Given this list of marker genes Nup62, Gpc4, Chsy3 (NCBI Gene Id 78923), B3gat2, Gpi1, Bpgm, Gns, Fut2, Tpi1, Stab2, Pfkfb2, Lalba, Chst11, Ogn, Chst13, Gpc3, Cryl1, Chst7, Abcc5, Fut4, B3galt2, Sdc1, Pfkl, Gck, Nup37, Pfkfb3, Sec13, Pygl, Lum, Khk, Pgm1, B4galt2, Chp1, G6pc2, Dcxr, B4galt7, Gpc2, Glb1l3, Ndst1, Fut1, Nup43, Nup214, Gapdhs, Pkm, Uxs1 (NCBI Gene Id 98712), Ugp2, Gckr, Sdc2, Gpc1, Akr1e1, Pygm, Agrn, Fbp1, Pgm2, Prelp, G6pdx, Hpse2, B4galnt2, Tkt, Prps1l1, Glb1, Eno4, Chst3 (NCBI Gene Id 53889), Gpc6, Nup205, Xylt2, Slc37a4, Has3, Hexa, Slc37a1, Papss2, Hs6st3, Csgalnact2, Fut7, Pfkm, Hmmr, Shpk, St3gal2, Dse, Slc9a1, Chst12, Ext1, Hs2st1, Chst5, Sgsh, Slc37a2, Man2b1 (mannosidase 2, alpha B1), B4galt1, Phka2, Seh1l, Pgd, Ndc1, Galk1, Hk3 (hexokinase 3), Bgn, Nup93, Xylb, Ids, Gpc5, Cemip, Kera, Xylt1, B3gnt3, Abo, Chst1, Prps1, Pgk2, Ust, Rpia, Hs3st3b1, Chpf, Aldob, B4galt3, Pfkfb4, Taldo1, Nup160, Omd, Agl, Nup42, Rae1, Glb1l2 (galactosidase, beta 1-like 2), Slc35d2 (NCBI Gene Id 70484), Nup35, Pgk1, Aldoc, Sord, Pgm2l1, Galns, Hs3st1, St3gal3, Tkfc, Galm, Chst2, Phkg1, Dera, Pck1, Nup88, Pcx, Man2c1, Hpse, Cspg5, Slc35b2, B4galt5, Fmod, Papss1, Tpr, Bcan, Prps1l3, Gale, Gbe1, Hs3st6, Slc26a2, Nup210 (NCBI Gene Id 54563), St3gal1, Calm1, Acan, Galt (galactose-1-phosphate uridyl transferase), Fut9, Csgalnact1, Ndst4, B3galt6, Sdc4, Hyal2, Manba, B3gnt2, Pfkp, B3gat1 (beta-1,3-glucuronyltransferase 1), Slc26a1, Ndst3, Pgam1, Hs3st5 (heparan sulfate (glucosamine) 3-O-sulfotransferase 5), Gaa, Chst15, Chsy1, Cd44, Nup133, Chst14, B4galt4, Pgls, Nup153, Aldh1a1, Naglu, Vcan, Calm2, Cspg4, G6pc1, Hyal1, Nup188, Rbks, Dsel, Aldoa (aldolase A, fructose-bisphosphate), Arsb (NCBI Gene Id 71784), Gnpda2, Hexb, B3galt4, Chpf2, Pgam2, Gnpda1, B4galt6 (NCBI Gene Id 56386), Lyve1, Eno3, Prps2, St3gal4, Nup107, Has2, Phkb, Eno2, Hs3st2, Gapdh, Hk1, Glb1l, B4gat1, Nup85, G6pc3, Dcn, Glyctk, B3galt5, Sdc3, Pom121, Pck2, Fbp2, St3gal6, Nup54, Akr1b1, Gyg1, Hgsnat, Pfkfb1, B3gnt7, B3galt1, Phka1, Akr1a1, Man2b2, Gys1, Calm3, Nup98, Rpe, B3gat3, Hk2, B3gnt4, Slc2a1, Hs3st3a1, Nup155, Phkg2, Hs6st2, Ext2, St6galnac6, Has1, Nup50, Hkdc1, Hyal3, Chst9, Hs6st1, Ranbp2, Adpgk, Gusb, Nup58, Ndst2, Ppp1r3c, Slc35b3, Aaas, Idua, Hs3st4 (heparan sulfate (glucosamine) 3-O-sulfotransferase 4), here is a description of the gene set: Mouse Gene Set: REACTOME_METABOLISM_OF_CARBOHYDRATES_AND_CARBOHYDRATE_DERIVATIVES species: Mus musculus Metabolism of carbohydrates and carbohydrate derivatives